Given this list of marker genes TCP1, PVT1, TUSC3, DEDD, E2F6, EFCAB7 (EF-hand calcium binding domain 7), RBM34, MSRB2, ARL4A, CCDC91, GNPDA2, BBS2, SPAG7, HNRNPC, RFC3, CUL4B, ATG10, LILRB4, CPSF3, DUSP1, MCM6, GART, CXCL10, GSTK1, POLR1E, CKLF, GLRA2, EBPL, NARS2, MRPL27, TRIM13, CD2AP, XRCC5, ASNSD1, E2F5, BRCA1, FBL, CD72, CD69, PSMD14, THBD, WWP1 (WW domain containing E3 ubiquitin protein ligase 1), IARS1, RNF168, IL15, INTS4, RAD18, RUNDC3B, ZNHIT6, HSD17B11, IFI27L1, DDHD2, GSTM1, SUGT1, SLC23A2, GADD45A, UTP14A, NDUFA9, ENO1, EIF2S2, CASP4, PSMG2, NME7, DNTTIP2, AIM2, SCRN3, PSMD10, CDK7, SAV1, MIR382, DPH5, EXOC3, DKC1, WDR53, PIK3CB (NCBI Gene Id 5291), ASCC1, PIGP, ASF1A, RNF130, PGM2, CETN3, IPO5 (NCBI Gene Id 3843), TRAPPC2, ADH5, PDLIM1, SLC25A4, USP18, GTPBP10, PITRM1, SGF29, C6orf89, GBA1, EIF3F, RFC2 (replication factor C subunit 2), SRFBP1, MRTO4, XCL1, IFNG, AIP, MCM7, GSDMD, DMRTA1, ETFDH, EIF3C, PPA2, EIF2A, DDX18, TTC27, WDR76, GTF2H2, PRSS12, GRK5, NDUFS2, MCOLN1, RNF149, RNASEH2A, PECR, CLNS1A, ABCG2, DDX56, GNPTG, TCEAL1, PRIM1, ZBTB6, PCGF1, TNFAIP8, CTSS, GSTP1, USPL1, CD7, AQP9, RING1, BSCL2, PRMT7, ANTKMT, AFG3L2 (AFG3 like matrix AAA peptidase subunit 2), GPR65, DDX52, MAP4K5, JAML, CD55, TBRG1, ZNG1A, ASAH1, RAB29, WDR36, GRIPAP1, TFAM, IFIT1, MRPL1, EEF1G (NCBI Gene Id 1937), SLC49A4, ISOC1, BCOR, KLHDC9, ARHGAP5, GINM1, INTS10, NOP58, UXS1 (UDP-glucuronate decarboxylase 1), KCTD5, BLVRA, MPHOSPH10, CWH43, PNP, PPP2R3C, GPR155, HSD17B8, LANCL1, MRPL42, APIP, here is a description of the gene set: Genes down-regulated in B lymphocytes with ZFX knockout: control versus stimulated by anti-IgM for 2h. Human Gene Set: GSE13547_CTRL_VS_ANTI_IGM_STIM_ZFX_KO_BCELL_2H_DN The development, homeostasis and function of B lymphocytes involve multiple rounds of B cell receptor (BCR)-controlled proliferation and prolonged maintenance. We analyzed the role of transcription factor Zfx, a recently identified regulator of stem cell maintenance, in B cell development and homeostasis. Conditional Zfx deletion in the bone marrow blocked B cell development at the pre-BCR selection checkpoint. Zfx deficiency in peripheral B cells caused impaired generation of the B-1 cell lineage, accelerated B cell turnover, depletion of mature recirculating cells, and delayed T-dependent antibody responses. Zfx-deficient B cells showed normal proximal BCR signaling, but impaired BCR-induced proliferation and survival. This was accompanied by aberrantly enhanced and prolonged integrated stress response, and delayed induction of Cyclin D2 and Bcl-xL proteins. Thus, Zfx restrains the stress response and couples antigen receptor signaling to B cell expansion and maintenance during development and peripheral homeostasis. from publication Arenzana TL, Smith-Raska MR, Reizis B (PMID 19329779) studied in species Homo sapiens